The following is a description of a gene set: Asymmetric head shape, which is usually a combination of unilateral occipital flattening with ipsilateral frontal prominence, leading to rhomboid cranial shape. Human Gene Set: HP_PLAGIOCEPHALY species: Homo sapiens Plagiocephaly, and this is the list of marker genes: MESD, TCF12, EIF4A2, FBXO11, TUBB3, TREX1, TWIST1, ERMARD, ZNF292, BMP4, POGZ, FOXP2, INPP5E, KIDINS220, SET, PPP2CA (NCBI Gene Id 5515), KMT2C, MAF, CNOT3, HERC2, TP53RK, KIF21A, H3-3B, ARX, COL25A1, SUPT16H, PKDCC, KRAS (NCBI Gene Id 3845), EMC10 (ER membrane protein complex subunit 10), RAC3, CHN1, FOCAD, RNU7-1, EML1, ADARB1, CLCN3, PIGO (NCBI Gene Id 84720), ARID1B, ANTXR1 (NCBI Gene Id 84168), PGAP2, LSM11, PRUNE1, PIGV, SCYL2, ALX4, EHMT1, DPYSL5, NRAS, TUBB2B, MAFB, MEG3, PPP3CA, FAM20C, CAMK2A, CDK13, UGDH, PIGA, POLR2A, FKTN, DPYS, TBC1D24 (TBC1 domain family member 24), CACNA2D1, PGAP3, CYFIP2, HRAS, GRIA1, PPP1R21, MBTPS2, CDC42BPB, TRPM3, CA2, RNASEH2B, RAB23, MADD, MEGF8 (multiple EGF like domains 8), SPTBN1, CHSY1, SMC3, NFIX, HNRNPH1, PIGL, COL11A2, WBP11, PIGW, MAPK1, PPP2R5D, RNASEH2C, SMARCA2, MN1, H3-3A, MED12, ATP2B1, CHAMP1, SLC26A2, NRCAM, ERGIC1, PRKAR1B, PIGQ, RNASEH2A, PIGY, KAT6A, RFX7, ADAR, PHF21A, B3GALT6, ZBTB20, AHDC1, NLGN4X, ALG12, ROBO3, TUBA1A, NEPRO, CCDC47, NONO, COL11A1, HEPHL1, SALL4 (spalt like transcription factor 4), MED13L, ZIC1, DHX37, RTL1, ZNF699, IFIH1, DYNC1H1, USP7, BLTP1, AGO2, PCGF2, RAC1, ARID2, FBXL4, STXBP1, NALCN, PPP2R1A, SAMHD1, MYMK, DLK1, CBFB, ATP6V1B2, WDR35, TCF20, EIF5A, ADNP, ADAT3, AFF4, PHOX2A, CUX1, UNC80, FGFR3, RNU12, GNPTAB, CASK, FGFR2, HNRNPK, EFNB1, TBCD, LMX1B